The following is a description of a gene set: The gene expression program underlying the specification of human cell types is of fundamental interest. The study authors generated human cell atlases of gene expression and chromatin accessibility in fetal tissues. For gene expression, the study authors applied three-level combinatorial indexing to >110 samples representing 15 organs, ultimately profiling ~4 million single cells. The study authors leveraged the literature and other atlases to identify and annotate hundreds of cell types and subtypes, both within and across tissues. Our analyses focused on organ-specific specializations of broadly distributed cell types (such as blood, endothelial, and epithelial), sites of fetal erythropoiesis (which notably included the adrenal gland), and integration with mouse developmental atlases (such as conserved specification of blood cells). These data represent a rich resource for the exploration of in vivo human gene expression in diverse tissues and cell types. Human Gene Set: DESCARTES_FETAL_STOMACH_STROMAL_CELLS from publication Cao J, O'Day DR, Pliner HA, Kingsley PD, Deng M, Daza RM, Zager MA, Aldinger KA, Blecher-Gonen R, Zhang F, Spielmann M, Palis J, Doherty D, Steemers FJ, Glass IA, Trapnell C, Shendure J (PMID 33184181) species: Homo sapiens Marker genes curated from the annotated cluster as represented in the Descartes Human Gene Expression During Development database., and this is the list of marker genes: COL1A1, ACTA2, NELL1, OSR2, SRPX, FBLN1, PDGFRA, EBF2, VSTM2A-OT1 (NCBI Gene Id 285878), SFRP2, DPT, TWIST2, PTCH1, MYH11, TRPA1, TAGLN, GLIS1, COL3A1, ANGPTL1, NRK, C7, CNN1, SCARA5, ITGA11 (integrin subunit alpha 11), COL6A3, FENDRR, ANGPTL6, EMILIN1, FOXF2, BMP5, FOXF1, TWIST1, PTGER1, PI16, TMEM119, CD248, PCDH18, DCN, HSPB6, GLYATL2, INHBA, MDFI, MFAP4, PLAC9, CAPN6, VSTM2A, CXCL14, LINC03007, ACTG2, SHISA3